The following is a description of a gene set: species: Homo sapiens Genes up-regulated in macrophages in response to LPS: naïve versus tolerant. Among the multiple mechanisms that control the intensity and duration of macrophage activation, the development of a state of refractoriness to a second stimulation in cells treated with LPS has long been recognized. Release of inhibitory cytokines and alterations in intracellular signaling pathways may be involved in the development of LPS tolerance. Although a number of molecules have been implicated, a detailed picture of the molecular changes in LPS tolerance is still missing. We have used a genome-wide gene expression analysis approach to (i) define which fraction of LPS target genes are subject to tolerance induction and (ii) identify genes that are expressed at high levels in tolerant macrophages. Our data show that in LPS tolerant macrophages the vast majority of LPS-induced gene expression is abrogated. The extent of tolerance induction varies for individual genes, and a small subset appears to be excepted. Compared to other negative control mechanisms of macrophages, e.g. IL-10-induced deactivation, LPS-tolerance inhibits a much wider range of transcriptional targets. Some previously described negative regulators of TLR-signaling (e.g. IRAK-M) were confirmed as expressed at higher levels in LPS-tolerant macrophages. In addition, we discuss other potential players in LPS tolerance identified in this group of genes. from publication Mages J, Dietrich H, Lang R (PMID 18086374) Human Gene Set: GSE8621_LPS_STIM_VS_LPS_PRIMED_AND_LPS_STIM_MACROPHAGE_UP, and this is the list of marker genes: UNC13D, FGF11, PLA2G5, HACD4, PF4 (platelet factor 4), ZNF808, ART1, RBM38, CRIPTO, OR2C1, OBP2B, APC2, CLEC1A (C-type lectin domain family 1 member A), TXNDC5, PLEKHF1, PACRG (parkin coregulated), DRAXIN, RYK, NDUFS5, CCDC3, MEDAG (NCBI Gene Id 84935), GSTM3, KLF7, SLC66A2, MYH6, COL4A5, KRT80, CYP4F2, KBTBD4, KLC2, PIGB, GRIP1, CSNK1D, RSPH6A (radial spoke head 6 homolog A), PAK6, BEND7, OPTC, KRT23, SHKBP1, GDF11 (growth differentiation factor 11), NUDT9, TMCC2, SERINC2, TRIR, RPL39L (ribosomal protein L39 like), VGLL2, HMGB3, PLA2G1B, PARM1 (NCBI Gene Id 25849), CPA3, BORCS5, CFAP126, EXOC3L2, ACTL7A, SCD, STXBP1, VAMP5, WASF1, NMNAT3, CACNA1H, PHLDA2, AQP9, TSR3, EPHB4, RIPOR1, EDAR, METTL6, PHF2, GIGYF1, ABCB8, CACNA2D1, CHIT1, PPP1R42, STRC, APBB2, C11orf86, FEZF1, ACOX2, RDH5, NME5, TMEM269, GP1BA, CLDN19, LRRC36, GJB1, GPR50, DNAJC11, FANK1, ETFB, P3H2, KIF3B, FOXN3, KRT8, CCDC25, HEMGN, EFCAB9, AKT2, AGPAT4, MLH3, THNSL2, RHOJ, ZSWIM2, CCN4, SH3RF2, NARF, HSPA12B, ANKRD1, CLTB, SIRT7, TUBA8, S100G, TMEM208, NAA35, INAFM1, MATN1, TSPAN4, KRT31, IGF2BP3, PDGFRA, XPA, RCN3, MICALL2, IGFBPL1, YPEL4, ARRDC1, TCF7, MOV10, STX3, EPB42, GNL1, PYGL, PRKAB1 (NCBI Gene Id 5564), RBP1, SPMIP9, RNF125, PLAAT3, SLC22A3, TEX12, DAPL1, CMTM7, SGPP2, EPYC (NCBI Gene Id 1833), ADGRB2, CHRNA4, NTN4, NRARP, PCMTD1, GCH1, VPREB3, CTNNA3, LIPT1, VILL, PON2, C8orf82, DPPA2, MON1A, NT5DC3, PRR13, MYH1, TMEM256, SLC10A1 (NCBI Gene Id 6554), BGN, VSX1 (NCBI Gene Id 8198), VAMP8, ZFPM1, ANO1, DNPH1 (2'-deoxynucleoside 5'-phosphate N-hydrolase 1), ZIM3, ADAM28, AKR7A2, HPS6, ITGA2B, MAEA, DGKI, CALR, SLC36A2, ARVCF, STXBP2, CCNJL, ABCG5, ITGA6, ARHGEF2, DAND5, FABP4, PIDD1, FBXL2, POLR2H, FGF3, CCDC54, ZFP3, TFEC, MBOAT2, LUZP2, SLC7A8 (NCBI Gene Id 23428), BCAT2, DNM1, GJA1, DRD3, HS3ST3B1, STAU2